The following is a description of a gene set: from publication Abe M, Sato Y (PMID 12197474) Genes up-regulated in HUVEC cells (endothelium) at 30 min after VEGFA stimulation. Vascular endothelial growth factor (VEGF) is one of the most important factors that stimulate angiogenesis and vascular permeability. To clarify the role of VEGF, we analysed a human cDNA chip containing 7267 human genes to identify genes induced by VEGF in human umbilical vein endothelial cells (HUVECs). One hundred thirty-nine cDNAs, including ninety-nine previously known and forty poorly characterized or novel sequences, were increased more than two-fold by VEGF within twenty-four hours of stimulation. Among them, only five are known to regulate angiogenesis: cyclooxygenase 2 (COX2), heparin-binding epidermal growth factor-like growth factor, early growth response 1 (EGR 1), CYR61, and angiopoietin 2. Fifty-three genes induced within the first two hours were thought to be directly induced by VEGF. Of these, Down syndrome candidate region 1 (maximum induction = 6.1-fold) was the most profoundly induced, followed by Mifl (KIAA0025; 5.5-fold), COX2 (4.7-fold), EGR 3 (3.7-fold), EGR 2 (3.2-fold), bactericidal/permeability-increasing protein (3.1-fold), and CD1B antigen, b polypeptide (3.1-fold). In addition to the genes mentioned above, there were many poorly characterized or novel genes induced by VEGF. Further analysis of these genes may aid in the elucidation of the molecular mechanisms of angiogenesis or vascular permeability stimulated by VEGF. Human Gene Set: ABE_VEGFA_TARGETS_30MIN studied in species Homo sapiens, and this is the list of marker genes: TKTL1, PTGS2, EGR2, PCDH17, BRINP1, VARS1, RCAN1, EGR3, TRIB1, CD1B, TAC1, AURKC, SCRN1, CCN1, PPY, KRAS, APOE, C2, ELAVL4 (ELAV like RNA binding protein 4), MCM2, MYO7A, GZMK, MPG, EGR1, HDC, NR4A1, ALAD, HBEGF, DUSP5